Given this list of marker genes Pcm1 (NCBI Gene Id 93826), Kif3a, Dctn1, Dag1, Clasp1, Nin, Ccdc120, Ninl, Gcc2, Bicd1, Gsk3b, Pex14, Cep43 (centrosomal protein 43), Cep350, Bccip, Clasp2, Ccdc68, Cep20, Map1s, Ccdc187, Bbs4 (NCBI Gene Id 52291), Hook3, Cep19, Camsap3 (NCBI Gene Id 69697), Bicd2, here is a description of the gene set: studied in species Mus musculus Any process in which a microtubule is maintained in a specific location in a cell. Mouse Gene Set: GOBP_MICROTUBULE_ANCHORING